The following is a description of a gene set: Genes up-regulated in comparison of monocytes from LAIV influenza vaccinee pre-vaccination versus those at day 7 post-vaccination species: Homo sapiens from publication Nakaya HI, Wrammert J, Lee EK, Racioppi L, Marie-Kunze S, Haining WN, Means AR, Kasturi SP, Khan N, Li GM, McCausland M, Kanchan V, Kokko KE, Li S, Elbein R, Mehta AK, Aderem A, Subbarao K, Ahmed R, Pulendran B (PMID 21743478) Human Gene Set: GSE29618_PRE_VS_DAY7_POST_LAIV_FLU_VACCINE_MONOCYTE_UP Systems vaccinology has emerged as an interdisciplinary field that combines systems wide measurements and network and predictive modeling applied to vaccinology. Here we used the systems vaccinology approach to study the molecular mechanisms underlying th, and this is the list of marker genes: CR2, DEPDC1, TPH1, PPP2R5D, AMPH, EN2, ZNF408, SLC8B1, LY6E, SFRP4, ARF3, ASCC2, FBXO46, CYLD, SERF2, ZBTB43, AMACR, GOLT1B, GSK3A, PCSK5, GTPBP2, SAP30BP, LILRB4, MTMR9, LGI2, SCHIP1, ADCY8, TFPT, PTPN7, COPB1, TFAP4, KRT85, CLDN14, UPP1, CHD1, ROPN1B, TRPV5, FGB, KCNA6, LMF1, ATP1B2, AMBN, PRPF8, MAL, PLPPR1, RARG, ORC1, CDC42EP1, TAPBP, TYROBP (transmembrane immune signaling adaptor TYROBP), TTYH1, RNF25, ERI3, MTOR, TSPAN7, CXCL12 (C-X-C motif chemokine ligand 12), CFAP68, SLC39A2, SH2B3, TPPP3 (NCBI Gene Id 51673), ADAMTS5, SMURF2, GLP1R, SYN1, CDK9, SUB1, COL4A3, CAMK1G, MYO1A, SH2D4A, GDNF, OR2H2, MC4R, CA9, NRBP1, HLA-DOA, TMCC2, ATG9A, PLEKHO2, SUMO2, RSPH14, DIXDC1, TIMP3, FOSL2, NFE2L1, ZNF334, BARD1, CD151, DDX41, LINC00474, RNASE2, CHST5, PAFAH1B2, MYDGF, PCDHB8, PART1, FBXO7, DCC (DCC netrin 1 receptor), SOCS3, ITPKC, KCNK5, PKP3, APBA3, CAMK1D, SLC3A1, PPBP, ELOA2, STIM1, SLC13A3, EBLN2, GMEB1, MFSD6, GNG5, WDR33, NUMA1, CLP1, NEAT1, TSC22D2, UBXN1, SUCLG2, GPR182, WNT5B, ERVMER34-1, DSCR4, LCE2B, RRAS, CEACAM6, CENPB, MYOZ3 (NCBI Gene Id 91977), IQSEC1, CD320, RASSF8, LOX, CIB1, PHLPP2, SCNN1D, TMPRSS15, CST1 (cystatin SN), ARPC3, CWF19L1, MEF2D, SH3BP2, DNAJC11, TSSK1B, UBAP1, MORC2, POLR2A, GS1-600G8.3, NFKBIE (NCBI Gene Id 4794), HPR, UNC13B, LINC01587, TEAD3, ARHGEF10, TYRO3, NCR1, KAT2A, NTN1, LRIG1, MYO1B, UBA6, P2RY11, TPSD1, SRM, IVD (isovaleryl-CoA dehydrogenase), HIF1A, NINJ2, DESI1, GSTA3, PXMP4, PATJ, RBM38, NSDHL, MNT, LIMK1, GLT8D2, GCLC, PI15, RAB4B, CEBPB, EPAS1 (NCBI Gene Id 2034), ZFAND6, AAGAB, MACF1, PBX3-DT (NCBI Gene Id 51145), ARL4C, MBTPS2 (NCBI Gene Id 51360), SMARCD3, TRAF6, ATP2B1, EMP3, AUNIP, ASB6, KIFC3, GUK1, SOD3, RPLP2